The following is a description of a gene set: from publication Zietara N, Łyszkiewicz M, Gekara N, Puchałka J, Dos Santos VA, Hunt CR, Pandita TK, Lienenklaus S, Weiss S (PMID 19581626) Genes up-regulated in CD8A+ splenic dendritic cells: wildtype versus IFNB1 knockout mice. Human Gene Set: GSE12392_WT_VS_IFNB_KO_CD8A_POS_SPLEEN_DC_UP Type I Interferons encompasses a large family of closely related cytokines comprising of at least 13 IFN-α isotypes and single IFN-β. Both IFN-α and IFN-β exert their activity through a common receptor IFNAR. Type I Interferons have broad regulatory effects and various subtypes of dendritic cells are influenced by this cytokines. In our study we asked question whether the low, constitutive levels of type I Interferons produced under steady state conditions are important for proper function of splenic conventional dendritic cells. species: Homo sapiens, and this is the list of marker genes: RPS6KA2, PAFAH1B3 (NCBI Gene Id 5050), PROSER2, AMMECR1L, PTGR3, FECH, RGS10, LPIN1, JPT2, SDC3, PLEKHO1, SNHG6, HADHB (hydroxyacyl-CoA dehydrogenase trifunctional multienzyme complex subunit beta), B3GNT5, PMM2, COA5, USP22, SNX1, KCTD12, MPC2, DBNDD2, CARD10, PHOSPHO2, LY96, GALNT7, LNPK, PI4K2A, PRKAB2, TWF1, LSR, ACADL, SLC33A1, OSTC, RIPK3, SOD1, HSP90B1, FGD6, CDK14, FAM117A, LIMK1, TOX4, CCNYL1 (NCBI Gene Id 151195), DPCD, DENND1B, COPS7A, SEC63, MYO18A, ANO6, GLIPR1, MRPL54, POGLUT2, PRR5L, SPTBN1 (NCBI Gene Id 91654), SLC37A3, GTF3C4, SLC30A7, TAF6L, DKK3, LAMTOR2, WDR3, SYNRG, ASAH1, ELOA, MRPL58, ALDOC, SH3TC1, ARHGAP22, RCBTB2, SUCLG1, DIP2A, PARP12, CCDC93, TOR3A, TLNRD1, IFT22, CTBP2 (NCBI Gene Id 87435), HBS1L, SWI5, MX2, DMAC1, PTBP2, BID, AP3S1, VRK2, BRK1, ASL, AGPAT3, PHC2, SSR4, FCHSD2, RFXAP (regulatory factor X associated protein), AKR1A1, TNFRSF21, DPAGT1, PRR5, CKB, SSX2IP, RNF7, SLAMF8, STAMBP, STT3A, NDST2, KCNK12, TXNDC9 (NCBI Gene Id 10190), S100A1, ESYT2, IPCEF1, EVL, DHRS1, PLPP2, B3GALNT2, OSBPL3, MAPK9, MYO9A (myosin IXA), SELENOS, TMBIM1, ACVRL1, PHB2, GLCE, GALNT10, STMP1, CNR2, ITM2C, PSMA3, CCT5 (chaperonin containing TCP1 subunit 5), CANX, PALS2 (NCBI Gene Id 55569), MAP3K4, CCR9, FDXR, C11orf54, HELLS, POLR1F, NDUFB11, SLC9A9, SLC35C2, SNX22, SCARB2, CSTB, MTIF3, FKBP2 (FKBP prolyl isomerase 2), CARS1, IL15, MTHFR, SCARB1, CYTH1, TRPV2, PIK3CB (NCBI Gene Id 5291), RAB39A, RRAGA, ERO1B, UBFD1, UBTD2, PTCD2, SLC25A13, PLBD1, SELENOI, PLEKHB2 (pleckstrin homology domain containing B2), OAZ2, GPRC5C, RAB11A, ALMS1, AP3D1, INSIG2, ACSS2, SELL, SEPTIN9, TBXAS1, MGLL, TMED2, RIMOC1, SLC41A2, AP1G2, MRPS21, ITGAL, TRIO, ACOX3, PHKA1, MAPK1IP1L, NUCB1, SRGAP2, DSEL, ARRB1, ARID2, NIBAN1, GGCX, ATP6V0E1 (ATPase H+ transporting V0 subunit e1), CD44, SELPLG, ZNHIT2, LRRC28, LRRC40, VCP, OXCT1, RPL28, ARSB, NDUFA9, SLC31A2, EXO5, ELOVL6